Given this list of marker genes VSX1, AGBL1, COL8A2, SLC4A11, OVOL2, TCF4, ZEB1, GRHL2, here is a description of the gene set: Human Gene Set: HP_REDUCED_NUMBER_OF_CORNEAL_ENDOTHELIAL_CELLS studied in species Homo sapiens A reduction in the number of corneal endothelial cells. Reduced number of corneal endothelial cells